Given this list of marker genes ABAT, APLN, PTGS2, HTR2A, TNFRSF11A, IL1B, PTGER3, PTGES, TNFSF11, NMU, TNF (tumor necrosis factor), ARRDC3, SLC27A1, EDNRB, here is a description of the gene set: Any process that modulates the rate or extent of heat generation. studied in species Homo sapiens Human Gene Set: GOBP_REGULATION_OF_HEAT_GENERATION